Given this list of marker genes MTERF3, MPV17L, MCAT, MRPS2, DDX28, METTL17, NGRN (NCBI Gene Id 51335), RCC1L, NOA1 (NCBI Gene Id 84273), MTG2, MIURF, FASTKD2, MTERF4, DHX30, MPV17L2, MRM2, MTG1, here is a description of the gene set: The aggregation, arrangement and bonding together of the mitochondrial ribosome and of its subunits. studied in species Homo sapiens Human Gene Set: GOBP_MITOCHONDRIAL_RIBOSOME_ASSEMBLY